The following is a description of a gene set: Any process that restricts, stops or prevents a cell from adopting a specific cell fate. studied in species Mus musculus Mouse Gene Set: GOBP_NEGATIVE_REGULATION_OF_CELL_FATE_SPECIFICATION, and this is the list of marker genes: Nanog, Fzd7, Dkk1, Sfrp2, Mesp1, Gfi1